The following is a description of a gene set: The covalent attachment of a palmitoyl group to a sulfur (S) atom within a cysteine residue to form peptidyl-S-palmitoyl-L-cysteine. studied in species Mus musculus Mouse Gene Set: GOBP_PEPTIDYL_L_CYSTEINE_S_PALMITOYLATION, and this is the list of marker genes: Zdhhc15, Zdhhc3, Zdhhc12 (zinc finger, DHHC domain containing 12), Golga7, Clip3, Zdhhc20, Zdhhc21, Zdhhc14, Zdhhc17 (zinc finger, DHHC domain containing 17), Zdhhc1, Zdhhc18, Zdhhc8, Zdhhc19, Zdhhc11, Zdhhc9, Zdhhc7, Zdhhc2